Given this list of marker genes Gpsm2, Numa1, Misp, Sapcd2, Epb41l2, Gnai1, Epb41, Plk1, Ppp1r9b, here is a description of the gene set: studied in species Mus musculus Mouse Gene Set: GOBP_REGULATION_OF_PROTEIN_LOCALIZATION_TO_CELL_CORTEX Any process that modulates the frequency, rate or extent of protein localization to cell cortex.